The following is a description of a gene set: species: Mus musculus Any process that activates or increases the frequency, rate or extent of ER to Golgi vesicle-mediated transport. Mouse Gene Set: GOBP_POSITIVE_REGULATION_OF_ER_TO_GOLGI_VESICLE_MEDIATED_TRANSPORT, and this is the list of marker genes: Sorl1, Stx18, Arf1, Pgap1, Tbc1d20